The following is a description of a gene set: Abnormality of the common coagulation pathway studied in species Homo sapiens Human Gene Set: HP_ABNORMALITY_OF_THE_COMMON_COAGULATION_PATHWAY An abnormality of blood coagulation, common pathway., and this is the list of marker genes: THBS2, PTPN22, MCM10, SERPINE1, STXBP2, ITGB2, CFI, PRF1, NLRC4, PTPN11, IRF2BP2, RARA, MAP2K1, STAT5B, F5, AHCY, MEFV (MEFV innate immunity regulator, pyrin), SPTA1 (NCBI Gene Id 6708), HRG, FIP1L1, UNC13D, BRAF, PLG, NABP1, XIAP, VKORC1, CD46, LMAN1, FGB, SLC4A1, HLA-B, STAT3, SPTB, F13B, NPM1, SLC7A7, NUMA1, PML, HELLPAR, ZBTB16, B4GALT1, HAVCR2, HLA-DRB1, P4HA2, TNFRSF9, CFH, MPI, TBL1XR1, GNA14, ALG6, FGG, MGAT2, EPB42, SLC37A4, F10 (coagulation factor X), MCFD2, ALG12, NGLY1, F13A1 (NCBI Gene Id 2162), PRKAR1A (protein kinase cAMP-dependent type I regulatory subunit alpha), BCOR, MPV17, FGA, ANO6, SLC19A1, SERPINC1, GGCX, LYST, ANK1, STX11